Given this list of marker genes RFC1, RPA2, RFC3, REV3L (REV3 like, DNA directed polymerase zeta catalytic subunit), UBA52, MAD2L2, PCNA, RPA3, UBC, RPS27A, RFC2, RPA1, RFC4, REV1, RFC5, UBB, POLI, here is a description of the gene set: studied in species Homo sapiens DNA polymerase iota (POLI) is a Y family DNA polymerase with an active site that favours Hoogsteen base pairing instead of Watson-Crick base pairing. POLI-mediated Hoogsteen base pairing and rotation of template purines from anti to syn conformation serves as a mechanism to displace adducts on template G or template A that interfere with DNA replication, or to allow base pairing of damaged purines with a disrupted Watson-Crick edge but an intact Hoogsteen edge.<p>POLI is recruited to DNA damage sites through its interaction with PCNA and REV1. POLI contains a PIP box and two UBMs (ubiquitin binding motifs) that are responsible for POLI binding to monoubiquitinated PCNA (MonoUb:K164-PCNA). The interaction between POLI and the C-terminus of REV1 is evolutionarily conserved.<p>After it incorporates a dNMP opposite to damaged template base, POLI is unable to efficiently elongate the DNA strand further. The elongation step is performed by the polymerase zeta complex (POLZ), composed of REV3L and MAD2L2 subunits. The involvement of REV1 and POLZ in POLI-mediated translesion DNA synthesis (TLS) suggests that POLI forms a quaternary complex with REV1 and POLZ, as shown for POLK and proposed for other Y family DNA polymerases. part of: Translesion synthesis by Y family DNA polymerases bypasses lesions on DNA template Reactome Pathway: Translesion synthesis by POLI